The following is a description of a gene set: Human Gene Set: GSE43956_WT_VS_SGK1_KO_TH17_DIFFERENTIATED_CD4_TCELL_DN Th17 cells are highly proinflammatory cells that are critical for clearing extracellular pathogens like fungal infections and for induction of multiple autoimmune diseases1. IL-23 plays a critical role in stabilizing and endowing Th17 cells with pathogenic effector functions2. Previous studies have shown that IL-23 signaling reinforces the Th17 phenotype by increasing expression of IL-23 receptor (IL-23R)3. However, the precise molecular mechanism by which IL-23 sustains the Th17 response and induces pathogenic effector functions has not been elucidated. Here, we used unbiased transcriptional profiling of developing Th17 cells to construct a model of their signaling network and identify major nodes that regulate Th17 development. We identified serum glucocorticoid kinase-1 (SGK1), as an essential node downstream of IL-23 signaling, critical for regulating IL-23R expression and for stabilizing the Th17 cell phenotype by deactivation of Foxo1, a direct repressor of IL-23R expression. A serine-threonine kinase homologous to AKT4, SGK1 has been associated with cell cycle and apoptosis, and has been shown to govern Na+ transport and homeostasis5, 6 7, 8. We here show that a modest increase in salt (NaCl) concentration induces SGK1 expression, promotes IL-23R expression and enhances Th17 cell differentiation in vitro and in vivo, ultimately accelerating the development of autoimmunity. The loss of SGK1 resulted in abrogation of Na+-mediated Th17 differentiation in an IL-23-dependent manner. These data indicate that SGK1 is a critical regulator for the induction of pathogenic Th17 cells and provides a molecular insight by which an environmental factor such as a high salt diet could trigger Th17 development and promote tissue inflammation. species: Homo sapiens from publication Wu C, Yosef N, Thalhamer T, Zhu C, Xiao S, Kishi Y, Regev A, Kuchroo VK (PMID 23467085) Genes down-regulated in CD4 T helper Th17 cells: wildtype versus SGK1 knockout., and this is the list of marker genes: CLEC4D, HRK, WAS, ANKRD40, SYNCRIP, PSMB5, XPO1, SNX14, FEM1B, TES, PTBP3, SLC25A53, RHOB, CDC42EP4, AARS1, PELI1, BCL2A1, VWF, PI4K2A, TWIST2, CSF2RA, NFE2L2, SLC4A1AP, CBFA2T2, EIF3D, SOS2, PRDX5, BRI3, C1D, MFSD14B, TSC22D1, ACOD1, MYH2, FPR2, AIFM1, AP3D1, B3GALNT2, SGK1, COX6A1, CEP350, MANF, CAB39, KCTD20, UBE2B, APBB1IP, GPR65 (NCBI Gene Id 8477), EGR1, ABCB8, DUSP1, MOV10, IL10 (interleukin 10), TNF, C2orf80, FCHO1, ATAD2B, REEP6, CISD1, HMBOX1, DUSP2, TSG101, CITED2, NEK7 (NCBI Gene Id 148565), NDST2, FOXK1, STRN3, ZBTB16, NAT2, GLO1, ZNF644, AHNAK, CNPY2, PTGER4, WSB1, SMIM7, CXCL2, PMM2, CCNG2, DIPK2A, AGFG1, TOR1AIP2, CNBP, MDM2 (MDM2 proto-oncogene), UTY, STX12, KLF6, IL1A, HYAL2, LPCAT3, IL4I1, PKLR, IL11RA, PTER, AMZ2 (archaelysin family metallopeptidase 2), GCH1, PAG1, MPHOSPH9, EFNB2, GCSAM, DYNC1H1, DDX18, MUC1, SNRNP27, ZC2HC1C, PCBP4, GAPDHS, GPR37L1, TRAK1, PTK7, TRIR, SNX4, BMP2K, ACSL4, ID3, PLA2G5, CLEC4E, NR1H3, CAPN7, CDV3, GSTT1, CBX5, TARBP2, ARF4, ERP44, LGMN, ATP13A3, MIEN1, TGIF1, OTULINL, TBC1D15, NOG, UBXN4, RCL1, PHC2, NREP, MKI67, PTPN11, MARCKS, PLIN2, CTNNB1, VPS45, BCL2L11, CST3 (NCBI Gene Id 1471), HNRNPR, EHD1, PEX2, ATP11A, SMAD4, RNF138, TULP4, MRPL24, UCHL5, FXYD5, SBF2 (NCBI Gene Id 81846), IL15RA, GADD45B, TMEM230, MAP3K3, GSTO1, CYFIP1, ZC3H12C, PDCD6, CXCL3, SUSD6, STX5, NIPBL, S100A11, SLC8A1, RBMS1, SLC38A2, GORASP2, PHLDA1, MMP13, RAB24, KPNA4, DNAAF10, TCF12, DUSP16, NTHL1, MCOLN2, OSER1 (oxidative stress responsive serine rich 1), UGCG, BMI1, SHD (NCBI Gene Id 56961), FOXN2, TRAF1, DNAJB6, HSD17B7, ZFAND2A, MRPL9, RBM39, NR4A1, CGGBP1, CDK14, TNIP1, IFRD1, CORO2B, MRAS, TAX1BP1, GTF2A1, HK2